Given this list of marker genes Tfeb, Rasgrp4, Nod2, Defb42, Nfkb1, Muc19 (NCBI Gene Id 667734), Il33, Marchf2, Mpeg1, Umod, Slc15a2, here is a description of the gene set: Mouse Gene Set: GOBP_ANTIBACTERIAL_INNATE_IMMUNE_RESPONSE species: Mus musculus An defense response against a bacteria mediated through an innate immune response. An innate immune response is mediated by germline encoded components that directly recognize components of potential pathogens.